Given this list of marker genes RBM17, MTCO3P12, ZNF620, CYP4F22, METTL26, LINC01965, SIGMAR1, ANO8, ACVR1C, COL6A4P2, MUC1, RNA5SP18, DLST, RPS7, SGSM1, ADCY6-DT, UTRN, FNBP1P1, TBC1D5, C1orf220, GALT (galactose-1-phosphate uridylyltransferase), TMBIM4, GTPBP3, DNAH10, SF3B2, PTPN21, DUX4L18, SEZ6L, LRRC8D, DAPK1, USP2, TP53I11, SLC23A1, ZNF219, VPS26A, IGSF23, TRIM8, LRP6, PXK, NEK7, FBXO44, ZNF143-AS1, SMG1P2, SDAD1P1, CBX3P4, LRRC8D-DT, MUC6, C11orf68, CCDC107, ST8SIA4, GNAQ, ZFAND3-DT, SUZ12P1, ANKRD10 (ankyrin repeat domain 10), ERGIC2, TRMT9B, ZNF584 (zinc finger protein 584), HLA-DMA, EIF2B4, ZBTB7B, POGK, FADS2, EPHB1, FABP5P3, TEFM, PLEKHM1, AREG, ADAP2, MTFR1L, MBNL3, MSI2, HERC5 (NCBI Gene Id 51191), THAP10, ZNF226 (NCBI Gene Id 82199), ALDOA, GNB4, HERPUD1, PDE3A, ZFP64, KMT2C, C1orf159, PGK1, LINC01387, CPT1A, POLD3, FKBP4, VDAC1, ARID1A, FOXN3, MT-TW, GCHFR, ZNF143, SHBG, ZFAND3, ZNF793, ADGRE1, TUBB2A, TRIM8-DT, PDE11A, GUSBP2, FGFR3 (fibroblast growth factor receptor 3), MTND5P11, PITPNC1, CERCAM, GBA1, SMARCD2, MYO1F, LINC00486, SAMD4A, PNRC1, LITAF, POU2F2, SAT2, WSCD2, TNKS2-DT, CACNB2, FBXL14, FAR2, GRHPR, MT-CO1, CLEC2L, LINC00240, SNX17, RNA5SP482, LIPT2, ACKR2, ADCY6, HIGD1A, LINC01596, KANSL3, IFI44L, CBFA2T2, EDARADD, LINC00882, VWA7, LINC01932, EDEM3 (ER degradation enhancing alpha-mannosidase like protein 3), CRYBG1, HCG15, LRRC49, HINT1, DOK4, GDPD5, KANK1, CXXC4, SEC14L6, NKX3-1, DRAP1, FRMD3, MT-TQ, MCRIP2, ANXA11 (NCBI Gene Id 311), GPR137, DUBR, TPBGL-AS1, PRICKLE2, BAD, here is a description of the gene set: from publication Yevshin I, Sharipov R, Kolmykov S, Kondrakhin Y, Kolpakov F (PMID 30445619) Genes containing one or more binding sites for (ZNF37A) in their promoter regions (TSS -1000,+100 bp) as identified by GTRD version 20.06 ChIP-seq harmonization. species: Homo sapiens Human Gene Set: ZNF37A_TARGET_GENES